Given this list of marker genes TBX1 (NCBI Gene Id 7413), FTO, IRX3, UCP1 (NCBI Gene Id 7350), ARID5B, PPARGC1A, IRX5, PRDM16, here is a description of the gene set: Human Gene Set: WP_FTO_OBESITY_VARIANT_MECHANISM studied in species Homo sapiens FTO obesity variant mechanism